The following is a description of a gene set: This event has been computationally inferred from an event that has been demonstrated in another species.<p>The inference is based on the homology mapping from PANTHER. Briefly, reactions for which all involved PhysicalEntities (in input, output and catalyst) have a mapped orthologue/paralogue (for complexes at least 75% of components must have a mapping) are inferred to the other species. electronically inferred by orthology from the curated human pathway studied in species Mus musculus Reactome Pathway: Signal attenuation part of: Insulin receptor signalling cascade, and this is the list of marker genes: Irs1, Mapk3, Ins1, Ins2, Irs2, Shc1, Grb2 (NCBI Gene Id 14784)